The following is a description of a gene set: Mapk cascade Mouse Gene Set: WP_MAPK_CASCADE studied in species Mus musculus, and this is the list of marker genes: Mapk10 (mitogen-activated protein kinase 10), Mapk1, Map3k12, Map2, Map2k4, Jun, Map3k3, Sipa1 (NCBI Gene Id 20469), Araf, Mbp, Hras, Rasa3, Elk1, Raf1, Map2k2, Map3k1 (mitogen-activated protein kinase kinase kinase 1), Mapk3, Plcb3, Kras, Mapk12, Nras, Map3k2, Mapk14, Map2k1, Map2k3, Braf, Map2k6, Rras